Given this list of marker genes CPEB4, AIMP2, PATL1, EPCAM, RHOB, here is a description of the gene set: from publication Caffarel MM, Moreno-Bueno G, Cerutti C, Palacios J, Guzman M, Mechta-Grigoriou F, Sanchez C (PMID 18454173) studied in species Homo sapiens It has been recently shown that cannabinoids, the active components of marijuana and their derivatives, inhibit cell cycle progression of human breast cancer cells. Here we studied the mechanism of Delta(9)-tetrahydrocannabinol (THC) antiproliferative action in these cells, and show that it involves the modulation of JunD, a member of the AP-1 transcription factor family. THC activates JunD both by upregulating gene expression and by translocating the protein to the nuclear compartment, and these events are accompanied by a decrease in cell proliferation. Of interest, neither JunD activation nor proliferation inhibition was observed in human non-tumour mammary epithelial cells exposed to THC. We confirmed the importance of JunD in THC action by RNA interference and genetic ablation. Thus, in both JunD-silenced human breast cancer cells and JunD knockout mice-derived immortalized fibroblasts, the antiproliferative effect exerted by THC was significantly diminished. Gene array and siRNA experiments support that the cyclin-dependent kinase inhibitor p27 and the tumour suppressor gene testin are candidate JunD targets in cannabinoid action. In addition, our data suggest that the stress-regulated protein p8 participates in THC antiproliferative action in a JunD-independent manner. In summary, this is the first report showing not only that cannabinoids regulate JunD but, more generally, that JunD activation reduces the proliferation of cancer cells, which points to a new target to inhibit breast cancer progression. Genes up-regulated in EVSA-T cells (breast cancer) treated with 3 micromolar THC (delta-9-tetrahydrocannabinol) for 8 h. Human Gene Set: CAFFAREL_RESPONSE_TO_THC_8HR_3_UP